Given this list of marker genes HPRT1, LRRK2, SLITRK5, ALDH1A3, OGDH, MKKS, BBS4, FOXP2, ZSWIM6, SHANK3, SLC7A11, FOXP1, DRD2, BBS2, INHBA (inhibin subunit beta A), SECISBP2, BCL11B, BBS1, DRD1, RARB, CNTNAP2, here is a description of the gene set: Human Gene Set: GOBP_STRIATUM_DEVELOPMENT The progression of the striatum over time from its initial formation until its mature state. The striatum is a region of the forebrain consisting of the caudate nucleus, putamen and fundus striati. species: Homo sapiens